Given this list of marker genes ABCG2, NEU1, CERS6, SGMS2, ARSI, FA2H (NCBI Gene Id 79152), CYB5B (cytochrome b5 type B), B4GALT5, CERS5, SMPD2, PRKD1, SPTSSA, SUMF1, SUMF2, SAMD8, ST3GAL5, GLB1, M6PR, ARSL, ALDH3A2, GLB1L2, ASAH1, ACER1, B3GALT4, ARSD, B3GNT5, GBA2, ACER3, PLPP2, ARSJ, FUT1, CERT1, ST8SIA5, UGCG, SMPD1 (NCBI Gene Id 6609), UGT8, ARSH, ASAH2, SPHK2, GALC, GLB1L, DEGS1, NEU3 (neuraminidase 3), FUT2, SPTLC3, CERS2, OSBP, VAPA, SGPL1, ABCC1, SGPP2, ST6GALNAC5, GBA1, MFSD2B, PRKD3, SMPD3, CERS4, PSAP, SPHK1, GM2A, ACER2, ARSF, ALDH3B1, ST6GALNAC6, GLB1L3, PLPP1, SGMS1, ARSK, ARSA, KDSR, ST3GAL3, CERK, NEU2, CTSA, SPTLC1, HEXA, CSNK1G2, CERS3, SPTLC2, HEXB, VAPB, STS, GBA3, CERS1, ORMDL3, B3GALNT1, B4GALNT1, PLPP3 (phospholipid phosphatase 3), SMPD4, GLA, PPM1L, SGPP1, ORMDL1, B4GALT6, ST3GAL2, ORMDL2, ENPP7, NEU4, ARSB, ALDH3B2, GAL3ST1, PRKD2, SPTSSB (NCBI Gene Id 165679), ARSG, A4GALT, SPNS2, DEGS2, here is a description of the gene set: Sphingolipids are derivatives of long chain sphingoid bases such as sphingosine (trans-1,3-dihydroxy 2-amino-4-octadecene), an 18-carbon unsaturated amino alcohol which is the most abundant sphingoid base in mammals. Amide linkage of a fatty acid to sphingosine yields ceramides. Esterification of phosphocholine to ceramides yields sphingomyelin, and ceramide glycosylation yields glycosylceramides. Introduction of sialic acid residues yields gangliosides. These molecules appear to be essential components of cell membranes, and intermediates in the pathways of sphingolipid synthesis and breakdown modulate processes including apoptosis and T cell trafficking.<p>While sphingolipids are abundant in a wide variety of foodstuffs, these dietary molecules are mostly degraded by the intestinal flora and intestinal enzymes. The body primarily depends on de novo synthesis for its sphingolipid supply. De novo synthesis proceeds in four steps: the condensation of palmitoyl-CoA and serine to form 3-ketosphinganine, the reduction of 3-ketosphinganine to sphinganine, the acylation of sphinganine with a long-chain fatty acyl CoA to form dihydroceramide, and the desaturation of dihydroceramide to form ceramide.<p>Other sphingolipids involved in signaling are derived from ceramide and its biosynthetic intermediates. These include sphinganine (dihydrosphingosine) 1-phosphate, phytoceramide, sphingosine, and sphingosine 1-phosphate.<p>Sphingomyelin is synthesized in a single step in the membrane of the Golgi apparatus from ceramides generated in the endoplasmic reticulum (ER) membrane and transferred to the Golgi by CERT (ceramide transfer protein), an isoform of COL4A3BP that is associated with the ER membrane as a complex with PPM1L (protein phosphatase 1-like) and VAPA or VAPB (VAMP-associated proteins A or B). Sphingomyelin synthesis appears to be regulated primarily at the level of this transport process through the reversible phosphorylation of CERT.<br> species: Homo sapiens part of: Metabolism of lipids Reactome Pathway: Sphingolipid metabolism